The following is a description of a gene set: Increased proteinogenic amino acid level in urine species: Homo sapiens Human Gene Set: HP_INCREASED_PROTEINOGENIC_AMINO_ACID_LEVEL_IN_URINE An elevated level of a proteinogenic amino acid in the urine. These are the 23 alpha-amino acids that are precursors to proteins, and are incorporated into proteins during translation. The group includes the 20 amino acids encoded by the nuclear genes of eukaryotes together with selenocysteine, pyrrolysine, and N-formylmethionine., and this is the list of marker genes: GUCY2D, NADK2, SLC6A18, GLYCTK, TAT, PRODH, MMADHC, PPM1B, MTR, SLC1A1, CAMKMT, SLC6A19, MCCC2, CBS, LMBRD1, MMACHC, ASPH (aspartate beta-hydroxylase), UQCRB, SUOX, PREPL (prolyl endopeptidase like), MTRR, SLC36A2, NFU1, SLC6A20 (solute carrier family 6 member 20), SARDH, SLC7A7, CLTRN, LIPT1, PRDX1, ACADM, ARG1, PCCA, SLC3A1, AASS, OPLAH, TDO2, ABCD4, IVD, MTHFR, GLDC, ALDH4A1 (aldehyde dehydrogenase 4 family member A1), PCCB, HCFC1, HAL, SLC7A9